The following is a description of a gene set: Human Gene Set: GOCC_GLYCOPROTEIN_COMPLEX A protein complex containing at least one glycosylated protein, may be held together by both covalent and noncovalent bonds. species: Homo sapiens, and this is the list of marker genes: PGM5, SNTA1, FLNA, SNTB1, SGCA, SNTB2, SGCE, SGCD, SGCB, SGCZ, SGCG, DMD, GP9, UTRN, SNTG1, SSPN (NCBI Gene Id 8082), GP1BA, GP1BB, KRT19, DAG1, CAV3 (caveolin 3), SNTG2, GP5